The following is a description of a gene set: Cis-regulatory QTLs (quantitative trait loci) found at the D6Mit150 region. from publication Chesler EJ, Lu L, Shou S, Qu Y, Gu J, Wang J, Hsu HC, Mountz JD, Baldwin NE, Langston MA, Threadgill DW, Manly KF, Williams RW (PMID 15711545) Human Gene Set: CHESLER_BRAIN_D6MIT150_QTL_CIS Patterns of gene expression in the central nervous system are highly variable and heritable. This genetic variation among normal individuals leads to considerable structural, functional and behavioral differences. We devised a general approach to dissect genetic networks systematically across biological scale, from base pairs to behavior, using a reference population of recombinant inbred strains. We profiled gene expression using Affymetrix oligonucleotide arrays in the BXD recombinant inbred strains, for which we have extensive SNP and haplotype data. We integrated a complementary database comprising 25 years of legacy phenotypic data on these strains. Covariance among gene expression and pharmacological and behavioral traits is often highly significant, corroborates known functional relations and is often generated by common quantitative trait loci. We found that a small number of major-effect quantitative trait loci jointly modulated large sets of transcripts and classical neural phenotypes in patterns specific to each tissue. We developed new analytic and graph theoretical approaches to study shared genetic modulation of networks of traits using gene sets involved in neural synapse function as an example. We built these tools into an open web resource called WebQTL that can be used to test a broad array of hypotheses. species: Mus musculus, and this is the list of marker genes: RHO, PHC1, SLC6A1, APOBEC1, A2M, ITPR1